The following is a description of a gene set: Any process that stops, prevents, or reduces the frequency, rate or extent of cardiac muscle cell proliferation. studied in species Homo sapiens Human Gene Set: GOBP_NEGATIVE_REGULATION_OF_CARDIAC_MUSCLE_CELL_PROLIFERATION, and this is the list of marker genes: MAPK11, VGLL4, NOG, MIR17HG, MIR199A1, MIR200B, MIR1-1, JARID2, SAV1, MIR199B, MIR873, RBP4, TBX5, TP73, KCNK2